The following is a description of a gene set: Mouse Gene Set: GOBP_NEGATIVE_REGULATION_OF_LIPID_LOCALIZATION Any process that stops, prevents or reduces the frequency, rate or extent of lipid localization. species: Mus musculus, and this is the list of marker genes: Atp5pf, Acsl4, Hbp1, Shh, Itgb3, Apoa2, Ppard, Akt1, Ces1h, Nrg1, Thbs1, Abhd5 (NCBI Gene Id 69842), Nfkbia, Mup2, Ces1g, Nr1h2, Ces1e, Apoc2, Mup11, Agtr2 (NCBI Gene Id 11609), Trem2, Kcnk9, Apoc3, Pla2r1, Mup5, Ces1c, Pparg, Ttc39d, Adipoq, Irs2, Asxl1, Irak1, Cry1, Ces1d, Apoc1, Abcg1, Pnpla2, Ttc39b (tetratricopeptide repeat domain 39B), Pcsk9, Mup1, Itgav, Crp, Ces1b, Ces1a, Apoc2l, Osbpl8, Tspo, Abca2, Nr1h3, Mup3, Ces1f, Acacb, Ppara, Pla2g10, Fis1, Egf, Hrh2, Ptpn11, Fxn, Ptpn2, Srebf2, Lep, Mup4, Clstn3, Cry2, Akt2, Igfbp3 (insulin-like growth factor binding protein 3), Apoe